Given this list of marker genes TRADD, FST, GAL, FOXN1, MSX2, WNT10B, KRT17, HPSE, TNF, TGFB2, NUMA1, WNT5A, here is a description of the gene set: Human Gene Set: GOBP_POSITIVE_REGULATION_OF_HAIR_FOLLICLE_DEVELOPMENT studied in species Homo sapiens Any process that activates or increases the frequency, rate or extent of hair follicle development.